Given this list of marker genes Pdcl3, Vegfd, Vegfa, Itgb3, Grem1, Cadm4, Cdh5, Dab2ip, Ccdc88a, here is a description of the gene set: species: Mus musculus Binding to a vascular endothelial growth factor receptor 2. Mouse Gene Set: GOMF_VASCULAR_ENDOTHELIAL_GROWTH_FACTOR_RECEPTOR_2_BINDING